The following is a description of a gene set: Mouse Gene Set: WP_FACTORS_AND_PATHWAYS_AFFECTING_INSULINLIKE_GROWTH_FACTOR_IGF1AKT_SIGNALING species: Mus musculus Factors and pathways affecting insulin-like growth factor (IGF1)-Akt signaling, and this is the list of marker genes: Tnfrsf1a, Pten, Igfbp7, Mtor, Rps6kb1, Jkamp, Smad3, Pdk1, Tnf, Nfkb1, Akt1, Igfbp2, Igf1r, Prkab1, Trim63, Igf1, Igfbp4, Acvr2b, Igfbp6, Smad2, Pld1, Igfbp3, Irs1, Igfbp5, Igfbp1, Foxo1, Mstn, Ilk, Tnfsf9, Itgb1, Ppargc1a